The following is a description of a gene set: Genes down-regulated in speen B lymphocytes: marginal zone versus follicular. from publication Feng J, Wang H, Shin DM, Masiuk M, Qi CF, Morse HC 3rd (PMID 21178004) Conditional IRF8 KO mice (mice with a conditional allele of Irf8 crossed with CD19-Cre mice) showed increased numbers of both Gene expression data spleen marginal zone (MZ) and Gene expression data spleen follicular (FO) B cells compared to control mice. To evaluate gene expression patterns that distinguished FO or MZ B cells derived from conditional KO and control mice, we used Affymetrix GeneChip® Mouse gene 1.0 ST Array. species: Homo sapiens Human Gene Set: GSE24972_MARGINAL_ZONE_BCELL_VS_FOLLICULAR_BCELL_DN, and this is the list of marker genes: SLC7A14, FRMPD2, AUH, INHBA, COPS8, AFDN, ZFP30, FCGRT, IKZF3, KRT6A, CD151, GPR84, LYL1, TSNAXIP1, NFKBIZ, SWAP70, NUMBL, TSNAX, RPL18, BEX4, CTNND1, NIBAN3, TAF5L, ATP13A3, C17orf58, THOC3, KCTD5 (NCBI Gene Id 91152), TCP10L, C1orf185, ZNF777, A4GNT, EPHX2, FN1 (NCBI Gene Id 2335, fibronectin 1), TMEM174, ARX, ZNF276, COL4A6 (collagen type IV alpha 6 chain), ALDOB, SMIM11, CHRNA5, ALX4, CXCL6, CHP2, GPR6, PFKL, FBXO5, DNAJC27, NICOL1, API5, OOSP2, NFATC2, STK33, SH2D2A, GREB1, SIGLEC1, NTN5, GNAT1, SGPP2, TMEM163, KLHL24, CETN1, SLAMF1, BCL7C, CCDC65, ZNF169, CYP11A1, ARG2, SESN1, NIPA1, SNAI3, CX3CR1, SALL3, CFB, ORAI1, PPM1A (protein phosphatase, Mg2+/Mn2+ dependent 1A), WNT6, MYO7B, FUT11, FNBP1, FGF17, P2RX1, CUEDC1, TMEM9, TLE1, KNTC1, RAPGEF5, LYSMD1, ELAPOR1, TRIM28, PLA1A, KMT5B, NBR1, PLD4, TLCD3B, IQGAP2, NUP133, CCND1, NXPE2, SKAP1, UCHL1, BET1, SEMA4A, CCL17, CELF6, FASLG, PLAC8, IDH2, CYP2W1, SRD5A1, GATB, IGHM (immunoglobulin heavy constant mu), TINAG, MRPS16, CAMP, SPAG4, ST8SIA6, ICOSLG, NECTIN1, GINS2, CIDEA, TIPIN, LYPD3, PLCB4, DDX23, CTDSP1, HS3ST1, HLA-A, GMFG, RBFOX3, ICAM1, KLF2, BARHL2, CD3G, TBC1D22B (TBC1 domain family member 22B), FRMD6, FPR1, ATP5ME, CASTOR1, IER3, RDH12, PHLPP1, DNAJC18, DUSP19, CPNE5, MGAT4A, CARMIL2, SLC2A12, SLC35G1, ZNF319, SLC6A13, MCM10, SREK1, TNFRSF9, ADAM11, LCE2B, HEPHL1, ALOX12B, PPIF, STK40, FANCC, SASH1, THAP7, AIF1, HSD3B2, CTLA4, PPFIA3, MAT1A, APOC4, NPHP3, FAM32A, PGP, MTCL2, CLK3, ULBP1, POLE2, AMIGO2, HR, B4GALT2, NUPR1, ALDH1A1, NR1H4, VAMP1, IL12RB1, USF3, SBK1, ANO3, ADAM2, CDC45, NBN, SIT1, FADS6, C16orf96, ONECUT1, DAB2, RPAIN, IL2RB (NCBI Gene Id 3602), PTGDR, SPMIP9, NAT8, NANOS1